The following is a description of a gene set: studied in species Homo sapiens Any process that stops, prevents or reduces the frequency, rate or extent of hematopoietic stem cell differentiation. Human Gene Set: GOBP_NEGATIVE_REGULATION_OF_HEMATOPOIETIC_STEM_CELL_DIFFERENTIATION, and this is the list of marker genes: TMSB4X, TCF15 (transcription factor 15), N4BP2L2, HSPA9, NFE2L2